Given this list of marker genes Rac3, Numb, Lrrtm2, Slitrk3, Abi3bp (NCBI Gene Id 360036), Lrrtm1, Carmil3, Ube2m (ubiquitin-conjugating enzyme E2M), Cc2d1a, Dock4 (NCBI Gene Id 70756), Elmo1, Fgfr1 (fibroblast growth factor receptor 1), Mark1, Nckipsd, Caskin1, Sptbn2, Prickle2, Sema4c, Nlgn2, Csmd2, Dock1, Dcx, C1ql2 (complement component 1, q subcomponent-like 2), Rtn4r, Dclk1, Flrt2, Zdhhc8, Neurl1a, Abl1, Pten, Iqgap1, Fam107a, Nptx1, Magi2, Cpeb3 (NCBI Gene Id 208922), Crk, Slc12a5, Numbl (NCBI Gene Id 18223), Rtn4, Arhgap33, Vps35, Pum2, Htr4, Zdhhc12, Wnt5a, Shank3, Nrxn3, Nrxn1, Arhgef9, Ptpn1 (protein tyrosine phosphatase, non-receptor type 1), Reln, Rac1, Ntng2, Dock10, Nedd8, Lrfn1, Arhgef15, Asic1, Crmp1, Dock7, Ntrk3, Cdh2, Gna13, Lrp4, Lrrc4b, Afdn, S1pr2, Cyfip2, Lats1, Asic2, Trim47 (tripartite motif-containing 47), Abi3, Lzts3, Il1rap, Nlgn3, Gap43, Ptk2b, Lzts1, Nrxn2, Map1b, Cript, Syndig1, Cbln1, Nectin3, Srgap3, Sigmar1, Crkl, Ptprs, Ephb2, Prickle1 (prickle planar cell polarity protein 1), Ppp1r9b, Lrfn4, Nptxr, Grid2, Sipa1l1, Ube3b, Ptprd, Psd, C1ql3, Nlgn1, Rhog, Nae1, Usp9x, here is a description of the gene set: Mouse Gene Set: GOBP_POSTSYNAPSE_ASSEMBLY species: Mus musculus The aggregation, arrangement and bonding together of a set of components to form a postsynapse.